Given this list of marker genes SHISA9, BCAS1 (NCBI Gene Id 8537), CPEB2, MARCKSL1, OGG1 (NCBI Gene Id 93577), SS18L1, LAMC1, MAN1A2, MEX3C, MR1, DNAH2, ENSG00000266560, C1QTNF3, TRIM9, MAGEA5P, SLC2A12, LDB3, DNAJC14, RHOA, ZNF451, PUDP, RBMS3, RPS6KB1, MARCKS, PIK3CA, LRP1, KIRREL2, CNNM3, RRAS2, PTGFRN, RPS6KA3 (NCBI Gene Id 6197), CIT, CAMK1D, AFF1, ABLIM2, IBTK, STX4 (NCBI Gene Id 6810), TIRAP, CTBP2, DIO1, UNC119B, OSBPL2, PLIN1, NEDD9, TASOR, ADAM12, EPHA3, RANBP10, ZNF597, CSDE1, TSPAN9, here is a description of the gene set: Genes predicted to be targets of miRBase v22 microRNA hsa-miR-4529-5p in miRDB v6.0 with MirTarget v4 prediction scores > 80 (high confidence targets). species: Homo sapiens from publication Chen Y, Wang X (PMID 31504780) Human Gene Set: MIR4529_5P